Given this list of marker genes Adra1b, Adra1d, Chrna7, Calca, Adra1a, here is a description of the gene set: studied in species Mus musculus Mouse Gene Set: GOBP_REGULATION_OF_SYSTEMIC_ARTERIAL_BLOOD_PRESSURE_BY_CAROTID_SINUS_BARORECEPTOR_FEEDBACK The process that modulates blood pressure by sensing the amount of stretch occurring in large arteries and responding to the input via central nervous system control.